Given this list of marker genes RPL26L1, SEM1, RPL37, RPL35A, RPS13, RPS12, RPS19 (ribosomal protein S19), PSMA3, ANKZF1, RPS26, RPS27, PSMB4, LTN1, PSMA6, TCF25, UBB, PSMA7, 18S rRNA, PSMD12, PSMD2, TRIP4, PSMD11, PSMB2, RPS15, RPL19, RPL8, RPL36AL, PSMB1, RPL35, RPL22, ASCC2, RPSA, 5S rRNA, RPS7, PSMA1, KLHDC10, NPLOC4, UBE2D1, PSMC1, RPL10L, RPS4Y2, PSMD1, 5.8S rRNA, RPS16, UBE2D2, RPS4X, RPL28, RPLP2, ADRM1 (NCBI Gene Id 11047), RPS4Y1, RPL9, FAU, RPL32, PSMB7, RPL23A, RPS21, RBX1, PSMC6, PSMC5, ELOB, RPS8, RPL5, RPL27A, RPS6, RPL29 (ribosomal protein L29), RPL13, PSMD3, RPL7A, RPL10, RPL26, PSMD6, RPL23 (NCBI Gene Id 9349), RPL6, RPS9 (ribosomal protein S9), RPS29, RPL11, RPL22L1, PSMA4, UBE2D3, RPL3L, PSMC4, PSMA2, CUL2, UBC, RPS10, PSMD13, RPL39L, RPS11, VCP, RPS28, PSMD7, PSMC3, PSMB3, ASCC3, RPL39, RPS25, UFD1, RPS3A, ABCE1, RPL21, RPS23, HBS1L, RPL4, PSMB5, RPS15A, RPL17, RPS3, ZNF598 (NCBI Gene Id 90850), 28S rRNA, RPS17, RPL10A, RPL31, RPS27A, RPL18A, RPS2, PSMD14 (proteasome 26S subunit, non-ATPase 14), RPL18, RPS20, PELO (NCBI Gene Id 53918), PSMC2, RPLP1, UBA52, RPL12, RPL34, RPL13A, PSMA5, RPL14, RPS18, NEMF, RPS24, RPS27L, RPL7, RCHY1, RPL15, PSMD8, RPS5, RPL41, RPL37A, RPS14, RPL36A, RPL3, RPL30, RPL36, RPL38, ELOC, PSMB6, RPL24, RPLP0, RPL27, here is a description of the gene set: species: Homo sapiens part of: Translation Reactome Pathway: Ribosome-associated quality control Features such as damaged nucleotides, strong secondary structure, presence of stretches of more than four uninterrupted AAA codons in a mRNA coding region (designated a no-go mRNA) or the absence of a stop codon in a mRNA (a non-stop mRNA) can cause a ribosome to stall during translation and the stalled ribosome can cause collisions with trailing ribosomes on the mRNA.<br>In cases in which the ribosome stalls internally on the mRNA and a 3' region of the mRNA protrudes from the ribosome, ZNF598, a ubiquitin E3 ligase that is the homolog of yeast HEL2, binds the ribosome and catalyzes the lysine-63 (K63) linked ubiquitination of the 40S subunit ribosomal proteins eS10 (RPS10) at residues K138 and K139 and uS10 (RPS20) at residues K4 and K8 to initiate splitting of the 40S and 60S ribosomal subunits. RACK1 then stabilizes the interface between the 40S subunits of the collided ribosomes to enable the ubiquitination of ribosomal proteins by ZNF598. RACK1 is also required for the recruitment of EDF1 which has been proposed by structural studies to stabilize the collision interface through a conserved KKW motif and an alpha-helical segment that clamps the mRNA. Additionally, EDF1 recruits the 4EHP-GIGYF2 complex to the collided ribosome to mediate translational repression of aberrant mRNAs, a mechanism which can also be initiated by ZNF598.<br>The ASCC2 subunit of the ribosome quality control trigger complex (ASCC, ASC-1 complex, ASCC2:ASCC3:TRIP4, homologue of the RQT complex in yeast) binds K63-linked polyubiquitin conjugated to the 40S protein uS10. The ASCC3 subunit of the RQT complex splits stalled 80S ribosomes with K63-polyubiquitinated uS10 into 60S and 40S subunits apparently by exerting a pulling force on the mRNA (inferred from the yeast homolog Slh1 in Best et al. 2023). The peptidyl-tRNA remains bound in the 60S subunit, with the tRNA positioned in the P site. The problematic mRNA dissociates after splitting and is thought to be degraded at this time. In the case of collided yeast ribosomes, the mRNA is first endonucleolytically cleaved and the cleavage products are exonucleolytically degraded by XRN1 and the exosome.<br>Non-stop mRNAs result in ribosomal stalls proximal to the 3' end of the mRNA, which are resolved by a distinct pathway. In this case, a complex comprising PELO, a paralog of the ribosome release factor eRF1, and HBS1L:GTP, a paralog of the ribosome release factor eRF3:GTP, binds the stalled ribosome near the subunit interface and the mRNA entry site. PELO:HBS1L preferentially acts on ribosomes that are bound to mRNAs that have fewer than 12 nucleotides extending 3' of the ribosomal P site.<br>HBS1L hydrolyzes GTP and dissociates from PELO and the ribosome, exposing a site on PELO to which ABCE1 binds. ABCE1 then hydrolyzes ATP to cause a conformational change that splits the ribosome into 40S and 60S subunits. ABCE1 and possibly the mRNA remain bound to the 40S ribosomal subunit, while the peptidyl-tRNA remains bound to the 60S ribosomal subunit as in the ASCC-mediated rescue pathway. <br>At this stage of either pathway, the 40S subunit can be deubiquitinated which may be necessary to license the 40S for further rounds of translation. In contrast, the 60S-peptidyl-tRNA complex requires additional steps to extract and destroy the nascent polypeptide before the 60S subunit can be recycled.<br>NEMF (the human homolog of yeast RQC2) binds the exposed peptidyl-tRNA of the isolated 60S ribosomal subunit produced by either the RQT complex or ABCE1 and transfers alanine residues from aminoacyl tRNAs to the C-terminus of the nascent peptide, a process termed Carboxy-terminal Alanine and Threonine tailing (CAT-tailing) after the alanine and threonine tails observed in yeast. Structures of CAT-tailing intermediates in yeast indicate that RQC2 positions an aminoacyl-tRNA in the A site of the 60S subunit and eIF5A enables peptidyl transfer.<br>The alanine C-terminal tails are believed to push the nascent peptide through the exit tunnel of the 60S ribosomal subunit to expose lysine residues for K48-linked ubiquitination by Listerin (LTN1), however alanine tails can cause aggregation of nascent peptides. The alanine tails can also act as degrons by binding the CRL2-KHDC10 ubiquitin E3 ligase complex or the RCHY1 (PIRH2) ubiquitin E3 ligase CRL2-KHDC10 and RCHY1 ubiquitinate the nascent peptide using K48 polyubiquitin linkages, targeting the nascent peptide for destruction by the 26S proteasome.<br>Listerin (LTN1, also called RKR1 in yeast), a ubiquitin E3 ligase, is also capable of catalyzing the K48-linked ubiquitination of the nascent peptide after NEMF recruits LTN1 to the 60S ribosomal subunit. The N-terminal region of LTN1 contacts the 60S ribosomal subunit and NEMF while the C-terminal region of LTN1 binds the 60S ribosomal subunit near the exit tunnel. TCF25 (the homolog of RQC1 in yeast) interacts with LTN1 (inferred from yeast homologs in Defenouillère et al. 2013).<br>LTN1 ubiquitinates exposed lysine residues on the nascent peptide after the residues have emerged from the exit tunnel of the 60S ribosomal subunit. TCF25, the human homolog of RQC1 in yeast, interacts with the RING domain of LTN1 to orient the ubiquitin substrate molecules to produce lysine-48 (K48) linkages in the polyubiquitin product.<br>A hexamer of VCP subunits plus a heterodimer of UFDL1 (UFD1) and NPLOC4 bind polyubiquitin that contains lysine-48 linkages (K48polyUb) and is conjugated to the nascent peptide emerging from the exit tunnel of the 60S ribosomal subunit. In yeast, the Npl4:Ufd1 heterodimer (homolog of NPLOC4:UFD1L) acts as an adapter that binds K48-linked polyubiquitin and inserts it into the pore of the VCP hexamer (inferred from rat p97 and Ufd1:Npl4 in Meyer et al. 2000, reviewed in Meyer and van den Boom 2023).<br>ANKZF1, which interacts with VCP, cleaves the C-terminal 3 nucleotides, CCA, of the tRNA in the peptidyl-tRNA bound to the 60S ribosomal subunit, yielding a free tRNA and the nascent peptide covalently bound to the CCA sequence. In yeast, Arb1 (mammalian ABCF2) occupies the E-site of the collided ribosome, extending a domain towards the peptidyl-tRNA that may help position it for release by Vms1/ANKZF1.<br>The VCP hexamer then extracts the ubiquitinated nascent peptide from the 60S ribosomal subunit. Six subunits of VCP surround the substrate protein, which is located in the central pore of the hexamer. Hydrolysis of ATP by a subunit causes it to disengage from the hexamer. Release of ADP and binding of ATP causes the subunit to rebind the hexamer more proximally to the 60S ribosomal subunit. The result is a ratcheting effect that withdraws the nascent peptide from the 60S subunit. The extracted nascent peptide remains bound to the ribosome-associated quality control complex (RQC complex, LTN1:NEMF:TCF25:VCP hexamer) which dissociates from the 60S ribosomal subunit and escorts the nascent peptide to the proteasome (inferred from yeast homologs in Defenouillère et al. 2017). The region of the nascent peptide that is unfolded by the VCP hexamer is able to enter the proteasome, resulting in degradation of the nascent peptide (inferred from the yeast homolog CDC48 in Olszewski et al. 2019). After removal of the ubiquitinated nascent peptide and tRNA, and mRNA, the 60S subunit is able to be re-used in translation. The 40 S subunit is deubiquitinated by OTUD3 and USP21.